Given this list of marker genes Prkdc, Smad4, Cep76, Csrp2, Stil, Ddx3x, Clasp1, Zfyve1, Xrcc5, Patl2, Brix1, Nop53, Ldb3, Golga2, Tnf, Cetn2, Aurkb, Misp, Atxn2l, Rho, Edn1, Ska2, Aurka, Cflar, G3bp1, Capn3, Eif4enif1, Neurl2, Rpl24, Rbm14, Casq1, Cep63, Hnrnpu, Lsm14b, Sqstm1, Pdgfra, Tpx2, Ccnb2, Ccdc61, Msn, Ccdc69, Haus6, Zar1, Flii, Ppp2r1b, Eml3, Dync1h1, Washc1, Mcidas, Rps27, Cenph, Jmjd6, Prox1, Mapk15, mt-Rnr1, Tmod2, Nkx2-5, Cep120, Kat2a, Eral1, Wdr1, Negr1, Tmod4, Edc3, Mapk8, Mrps2, Incenp, Arhgef10, Mapre3, Ncor1, Arhgef2, Rab11a, Hspa1b, Ccsap, Pls1, Prrc2c, Tnnt3, Tpr, Rpsa, Pdgfrb, Ythdf2, Kifc5b, Uhrf1, Rps6, Pspc1, Rpl11, Six4, Ezr, Actg1, Ino80, Ubap2l, Mybpc1, Spice1, Cav3, Sbds (SBDS ribosome maturation factor), Mterf4, Noct, Cds2, Aup1, Bicd1, Prc1, Pibf1, Hdac2, Neb, Mybph, Ythdf3, G3bp2, Birc5, Wrap73, Ythdf1, Rc3h1, Cnot6, Cep72, Arhgef5, Prickle1, Cenpk, Flnc (filamin C, gamma), Tcap, Smc3, Pisd, Bop1, Tubb5, Mypn, Ankrd23, Mdm1, Arpc2, Lcp1, Bscl2, Sh3pxd2b, Mybpc2, Tnnt2, Limd1, Rrp7a, Cnot6l, Rpl5 (ribosomal protein L5), Washc5, Ccdc15 (coiled-coil domain containing 15), Kifc1, Rpl38, Trim37, Patl1, Chmp1b2, Myoz2, Lmod2, Poldip2, Krt19, Surf6, Gsn, Eif5b, Noa1, Smc1a, Mterf3, Eif1ax, Flna, Mrm2, Mapk9, Alkbh5, Abt1, Ripor2, Csrp3, Ddx6, Cnot7, Rcc1l, Rpf2, Pqbp1, Klhl41, 4933427D14Rik, Lzts2, Trappc12, Dbnl, Cep295nl, Rps15 (NCBI Gene Id 20054), Lsm14a, Chmp7, Stag1, Mef2c, Cdca8, Sac3d1, Kat2b, Mlh1, Myh11, Dhx37, Ddb1, Bin2, Cfl2, Eif1a, Rps23, Cds1, Haus7, Clasp2, Cenpe, Cep135, Fus, Prkaa2, Rps3, Rps27l, Caprin1, D7Ertd443e, Csrp1, Ago2, Rnf213, Diaph3, Chmp4c, Mapre1, Myl2, Asb2, Aspm, Racgap1, Synpo2l, Fmr1, Pum2, Mospd2, Ccdc66 (NCBI Gene Id 320234), Map10, Chmp5, Krt8, Adprhl1, Dlgap5, Kash5, Nsun4, Casq2, Rttn, Fhod3, Rps28, Myh10, Nbdy, Haus8, Dcaf13, Abraxas2 (BRISC complex subunit), Gpsm2, Kif15, Cdk2, Alms1, Eif2a, Nek2, Lmod1 (NCBI Gene Id 93689), Chek2, Wnk1, Kif3b, Nrap, Khdc3, Stard9, Cntrob, Eif5, Tia1, Ndc80, C2cd3, Styxl1, Ngrn, Cnot1, Pan3, Spag5, Mettl17, Haus2, Smim22, Efl1, Cenpa, Sugt1, Rrs1 (NCBI Gene Id 98201), Tubgcp6, Fscn1, Mzt1, Dazap2, mt-Rnr2, Numa1, Rnf4 (ring finger protein 4), Myom2, Rpl10l, Bcas2, Kntc1, Ang, Cep192, Mcat, Mef2a, Liat1, Tnrc6a, Hdac3, Abraxas1, Csnk1d, Poc5, Cenpc1, Dhx29, Hsf1, Ldaf1, Tmod1, Stag2, Ddx28, Cenpj, Hif1a, Hck, Ppp1r35, Nup62, Fxr1, Mrto4, Kif2a, Chmp6, Vps4b, Kpnb1, Zfp207, Tns3 (tensin 3), Src, Cep97, Cirbp, Csde1, Mybpc3, Ppp2r1a, Chmp3, Drg1, Cep44, Cetn1, Cdc20, Poc1b, Fitm1, Senp6, Map9 (microtubule-associated protein 9), Vil1, Cnot2, Lsm4, Hspa1a, Prkd1 (protein kinase D1), Plk2, Cenpw, Kif23, Lmod3, Cltc, Bmp10 (NCBI Gene Id 12154), Lsm3, Myom3, Tnnt1, Grb7, Snhg15, Mapre2, Fitm2, Gtf2b, Chmp2b, Rps5, Becn1, Pwp2, Cenpt, Ccdc78, Acta1, Bccip, Ttn, Itgb1, Pten, Actc1, Cep295, Tubgcp4, Cep85, Chmp1a, Myh6, Csf2, Fbxo5, Haus1, Chmp1b, Myl9, E2f4, Ofd1, Prkaa1, Septin1, Aaas, Cdc20b, Cdk5rap2, Kif11, Ep300, Ogfod1, Mylk3, Deup1, Nop2, Cetn4, Tubgcp2, Nip7, Mpv17l2, Sass6, Pan2 (NCBI Gene Id 71734), Syt1, Wdr62, Actn2, Farp2, Tubgcp5, Fau, Eif2s1, Sqle, Rangrf (RAN guanine nucleotide release factor), Plk4 (polo like kinase 4), Cenpx, Dock5, Eif6, Chmp2a (charged multivesicular body protein 2A), Pogz, Srf, Plk1, Wdr90, Rps19, Kif9, Cavin4, Ar, Tubgcp3, Mfn2, Mybl2, Rhoa, D1Pas1, Xirp1, Pgm5, Haus5, Mrps7, Ska1, Ska3, Usp10, Mpv17l, Myom1, Kif4, Ccdc57, Mdn1, Fastkd2, Myoz1, Wnk3, Chmp4b, Tpm1, Haus4, Rcc1, Rps6-ps4, Tmod3, Npm1, Tubb1, Rps14, Pla2g4c (phospholipase A2, group IVC (cytosolic, calcium-independent)), Atxn2, Il5, C1qbp, Akap13, Haus3, Dicer1, Prkar1a, Ccp110, Dhx30, Cep152, Nebl, C9orf72, Atg5, Rps25, Mis12, Plec, here is a description of the gene set: The aggregation, arrangement and bonding together of a set of components to form a non-membrane-bounded organelle. Mouse Gene Set: GOBP_MEMBRANELESS_ORGANELLE_ASSEMBLY species: Mus musculus